The following is a description of a gene set: Mouse Gene Set: GOCC_SITE_OF_POLARIZED_GROWTH Any part of a cell where non-isotropic growth takes place. studied in species Mus musculus, and this is the list of marker genes: Sirt2, Lrp2 (low density lipoprotein receptor-related protein 2), Marcks, Gsk3b (NCBI Gene Id 98033), Dpysl3, Olfm1 (NCBI Gene Id 99427), Lamp5, Hdac5, Palld (palladin, cytoskeletal associated protein), Rufy3, Ptprs, Myo1a, Snap25, Disc1, Ngef, Inpp5j, Auts2, Cpeb1, Tiam1, Nin, Nrsn1, Lrrtm1, Nrp1, Aatk, Ptk2b, Stmn3, Amfr, Ptprf (NCBI Gene Id 19268), Exoc4, Sncb, Kif5a, Calm3, Ptch1, Crmp1, Prex1, Ppp1r9b, Ptprz1 (NCBI Gene Id 433999), Cotl1, Smo, Gprin1, Pink1, Dvl1, Cttn, Git1 (GIT ArfGAP 1), Apc, Fez1, Kif21a, Eno1b, Hsp90aa1, Usp9x, Dlg3, Exoc7, Pafah1b1, Tmod2, Igf2bp1, Ctnnd1, Timp2, Dbnl, Tenm2, Zfyve27, Ywhae, Hap1, Cobl, C9orf72, Rapgef4, Ccdc120, Ang, Kif21b, Arpc3, Dpysl2, Itga3, Scn11a, Adgrl1, Mapt, Tnk2, Cdk5r2, Whrn, L1cam, Orai1, Cdk5, Cables1, Rac3, Trpv2, Ctsz, Snca, Cfl1, Fgf13, Trpv4, Hnrnpr, Eno1, Katna1, Copg2, Shtn1, Kif3c, Ngfr, Dcc, Psen1, Cyth2, Chrna7, Kif20b, Frmd7, Cib1, Fkbp15, Arhgef7, Dynlt1b, Trak2, Acap3, Pcdh9, Dynlt1a, Arpc5, Abi1, Ighmbp2, Tiam2, Pclo, Sigmar1, Cxadr, Dcx, Eno2, Flrt3, Arhgap4, Unc5c, Shank2, Tsc1, Zpr1, Trpc5, Myh10, Cnr1, Cbl, Csnk1e, Als2, Map2, Cd2ap, Grin1, Klc1, Tor1a, Dynlt1f, Pi4k2a (phosphatidylinositol 4-kinase type 2 alpha), Kif5c, Eps8, Calm1, Gap43, Wdr47, Agrn (agrin), Gdpd5, Cbarp, Lrrk2 (NCBI Gene Id 79409), Cdk5r1, Cdkl5, Exoc3, App, Clasp2 (NCBI Gene Id 97514), Grm6, Crp, Orai2, Nectin1, Rasgrf1, Stim1, Fscn1, Iqgap1, Stmn2, Dctn2, Dicer1, Cpeb4, Setx (NCBI Gene Id 99309), Ppp1r9a, Fkbp4, Dclk1, Exoc6, Fryl, Gria2, Trak1, Hsp90ab1, Dbn1, Npcd, Ntrk2, Stx3, Map1b, Atcay, Dynlt1c, Abitram, Src, Lmtk2, Ptbp2, Katnb1, Gpm6a, Hcls1, Map3k12, Itga4, Rtn4r, Ndel1, Taok2, Fmr1, Limk1, Dnm2, Otx2, Slc2a13, Nefl, Smn1, Lrig2, Myo9a, Rapgef3, Dscam, Fry, Trpm1, Adcy10, Neo1, Mapk8ip1, Kif5b, Snx18, Crtac1, Basp1, Epha4, Apbb1, Tubb3, Calm2, Thy1, Ssh1, Pak1, Sirt1, Cxcr4, Ncam1, Copa, Boc, Zfp804a, Myh14, Erc2 (ELKS/RAB6-interacting/CAST family member 2), Ppp1r2, Cyfip1, Tshz3, Twf2, Flna, Arpc2, Mapk8ip3, Dtnbp1, Lrp1, Reg1, Nrxn1, Pard3, Tsc2, Syap1, Tpm3, Fscn3, Stmn4, Clu, Ndrg2, Elavl4, Pcdhgb1, Exoc8, Pard6a, Abl1